The following is a description of a gene set: Mitral valve prolapse Human Gene Set: HP_MITRAL_VALVE_PROLAPSE species: Homo sapiens One or both of the leaflets (cusps) of the mitral valve bulges back into the left atrium upon contraction of the left ventricle., and this is the list of marker genes: B3GALT6, HRAS, MED12, ADAMTS15, SPRED2, FMN2, NCF1, ALG9, PLD1, PRG4, IPO8, POLG, CHST14, EXTL3, TBX5, FBN2, CLIC2, ALG5, LZTR1, MFAP5, COL5A1, MLXIPL, GTF2IRD2, SH3PXD2B, GTF2IRD1 (NCBI Gene Id 9569), NDUFB11, PLOD1, ROBO1, VPS37D, ATP6V1E1, MAP3K7, BUD23, COX7B, FKBP6, TWNK, FIBP, HCCS, SMAD3, COL2A1, RYR1, AEBP1, TBL2, IFT140, PCGF2, BRF1, BMP4 (bone morphogenetic protein 4), HNRNPH2, PRDM5, STX1A, SMAD4, TGFB2, DSE, TGFBR2, MMP2, RPL5, EIF4H, BICC1, FLNA (filamin A), SKI (SKI proto-oncogene), COL1A1 (NCBI Gene Id 4970), SACS, DNAJC30 (NCBI Gene Id 84277), BAZ1B, SF3B4, XYLT2, LTBP3, B3GAT3, COL3A1, SELENON, GANAB, COL1A2, MYH7, RFC2, CHST3, GALE, CBS, BGN, BCOR, VPS13B, ABCC6 (ATP binding cassette subfamily C member 6), TMEM270, SLC6A6, TTN, DNAJB11, FMR1, EP300, NF1, AGR2, SLC29A3, PTPN11, CLIP2, PKD2, ANK1, ADNP, LIMK1, ELN, XYLT1, DCHS1, TAB2, HEXB, VWF, TPM3, KRAS (KRAS proto-oncogene, GTPase), MAPK1, NPR3, MMP14, PKD1, MYPN, CREBBP, METTL27, HCN4, COL5A2, SPRED1, ENPP1, FBN1, GTF2I, DZIP1, RAF1, BRAF, ZNF469, TPM2, LMNA, TNXB, TGFBR1